Given this list of marker genes NUMA1, PARD6A, CEP131, PIBF1, DCTN2, NUP62, CEP250, GOLGB1, APC, RAB11A, BICD1, NSFL1C, SPAG5, CCDC14, KIAA0753, UBXN2B, CEP350, RAB11FIP3, C2CD3, AURKA (NCBI Gene Id 8465), MAPRE1, CEP192, BBS4, DISC1, CEP83, STK3, CSNK1D (casein kinase 1 delta), HOOK3, MCPH1, NUDCD3, CEP72, PCM1, CEP78, MARK4, STIL, GSK3B, SNX10 (NCBI Gene Id 29887), TRIM69, here is a description of the gene set: A process in which a protein is transported to, or maintained in, a location within a microtubule organizing center. studied in species Homo sapiens Human Gene Set: GOBP_PROTEIN_LOCALIZATION_TO_MICROTUBULE_ORGANIZING_CENTER